Given this list of marker genes VEGFD, AFDN, SLC7A8, ANKS1B, PHEX, GABRD, CFD, NALF1, FMO2, LYPD6B, OLFML2A, here is a description of the gene set: from publication He P, Lim K, Sun D, Pett JP, Jeng Q, Polanski K, Dong Z, Bolt L, Richardson L, Mamanova L, Dabrowska M, Wilbrey-Clark A, Madissoon E, Tuong ZK, Dann E, Suo C, Goh I, Yoshida M, Nikolić MZ, Janes SM, He X, Barker RA, Teichmann SA, Marioni JC, Meyer KB, Rawlins EL (PMID 36493756) Human Gene Set: HE_LIM_SUN_FETAL_LUNG_C0_ALVEOLAR_FIBROBLAST studied in species Homo sapiens Alveolar fibro